The following is a description of a gene set: Cluster 4 of aberrantly hypomethylated genes in blasts from AML (acute myeloid leukemia) patients. from publication Figueroa ME, Lugthart S, Li Y, Erpelinck-Verschueren C, Deng X, Christos PJ, Schifano E, Booth J, van Putten W, Skrabanek L, Campagne F, Mazumdar M, Greally JM, Valk PJ, Löwenberg B, Delwel R, Melnick A (PMID 20060365) species: Homo sapiens Human Gene Set: FIGUEROA_AML_METHYLATION_CLUSTER_4_DN We hypothesized that DNA methylation distributes into specific patterns in cancer cells, which reflect critical biological differences. We therefore examined the methylation profiles of 344 patients with acute myeloid leukemia (AML). Clustering of these patients by methylation data segregated patients into 16 groups. Five of these groups defined new AML subtypes that shared no other known feature. In addition, DNA methylation profiles segregated patients with CEBPA aberrations from other subtypes of leukemia, defined four epigenetically distinct forms of AML with NPM1 mutations, and showed that established AML1-ETO, CBFb-MYH11, and PML-RARA leukemia entities are associated with specific methylation profiles. We report a 15 gene methylation classifier predictive of overall survival in an independent patient cohort (p < 0.001, adjusted for known covariates)., and this is the list of marker genes: EPHA2, ABI3, GBX2 (gastrulation brain homeobox 2), IL2RA (NCBI Gene Id 3559), GJC3, CTDP1, MED25, NQO2 (N-ribosyldihydronicotinamide:quinone dehydrogenase 2), PTPRS, CCR7, TACR3, CSGALNACT1, CEP350, ZNF853, GNGT2